Given this list of marker genes MTREX, DDX12P, DDX28, DDX52, IFIH1, DDX11L8, RIGI (RNA sensor RIG-I), EIF4A2, DDX5, DDX42, DHX29, DDX60L, DHX34, DDX51, DDX17, DDX56, DDX1, G3BP1, MOV10, DHX32, DDX10, DHX38, DHX35, FANCM, TDRD9, DDX43, TDRD12, SNRNP200, SKIC2, BRIP1, RAD54B, DHX57, DDX47, DDX21, HELZ2, DHX36, DHX33, PIF1, DDX20, DDX41, DHX8, EIF4A3, DDX18, DDX4, DHX58, DDX25, DDX19B, DHX15, DDX27, DHX37, DHX30, DDX50, DDX24 (NCBI Gene Id 57062), DDX39B (NCBI Gene Id 7919), YTHDC2, SUPV3L1 (NCBI Gene Id 6832), EIF4A1, DDX19A, DDX3X, DDX55, DDX31, DDX39A (NCBI Gene Id 95781), DDX59, DDX6, DDX3Y, MOV10L1, DDX53, UPF1, DDX11, DDX49, IGHMBP2, DHX40, DHX9 (NCBI Gene Id 3450), DDX60, DDX46, DDX54, AQR, DHX16, DDX23, here is a description of the gene set: Catalysis of the reaction: ATP + H2O = ADP + phosphate; this reaction requires the presence of RNA, and it drives another reaction. Human Gene Set: GOMF_ATP_DEPENDENT_ACTIVITY_ACTING_ON_RNA studied in species Homo sapiens